The following is a description of a gene set: Human Gene Set: GSE3982_EFF_MEMORY_VS_CENT_MEMORY_CD4_TCELL_UP In the present study we used Affymetrix oligonucleotide microarrays to produce gene transcription profiles for the major leukocyte types in humans. This comprehensive dataset enabled us to not only establish which genes were expressed in each leukocyte type, but also which genes were expressed in each subset after activation. The used of a comprehensive dataset of gene profiles from all the major human leukocyte subsets enabled a novel and powerful means for identification of genes associated with single leukocyte subsets, or different immune paradigms. species: Homo sapiens from publication Jeffrey KL, Brummer T, Rolph MS, Liu SM, Callejas NA, Grumont RJ, Gillieron C, Mackay F, Grey S, Camps M, Rommel C, Gerondakis SD, Mackay CR (PMID 16474395) Genes up-regulated in comparison of effective memory CD4 T cells versus central memory CD4 T cells., and this is the list of marker genes: EXTL2, MYH4, ZNF74, TUBB3, NECTIN3, TRPM2, FGR, GZMA, DOC2B, CD8B, DNAAF1, RNLS, MSH6, RUNX3 (NCBI Gene Id 864), GNLY, ENPP4, AGBL3, SUSD6, TFF3, IFNA6, CCND1, LUZP1, RASL10A, RFX2, SZT2, TRHDE (NCBI Gene Id 29953), DLX5, NLE1, TRAPPC14, CDIP1, SP3P, ORMDL2, SNAP91, GFI1, GZMK, ANXA2P2, GZMH, ST8SIA3, PIGZ, MAP2K6, AGPAT4, MRFAP1L1, SPATA7, FZR1, CAMKV, SIGLEC8, LBHD1, ERN2, H4C7, SPRED2, SRF, ITGAM, NR2F2, AMN, BDKRB2, BHMT2, E2F8, RAP1GAP2, TBX4, ERMP1, CABP5, PARP8, HPS1, NKG7, CD300A, NHLRC2, PHACTR4, ACTR3, ZDHHC14, ABCA3, PCOLCE, ISL1, PLA2G15, GAPDH, HLA-DPB1, ADGRV1, PHYH, LDLR, GFM1, SYNE2, PKP4, MCM2, CHKA, FOXA1, ELAPOR1, EIF3I, SLC25A42, VCL, SBSPON, HOPX, MYT1L, AZI2, RIMBP2, PCSK1N, CLTC, PLA2G4C, CLCA4, MAOB (monoamine oxidase B), SPON2, WEE1, DOCK6, CALM1, PLCB3, RBMS3, RSU1, CREB3, DACT1, TNC, CLIC1, KLRB1 (killer cell lectin like receptor B1), UBB, ADAMTS1, CCN1 (NCBI Gene Id 3491), TUBA1C, NEU2, AOAH, SRBD1, DGLUCY, G0S2, MATK, KEAP1, LPXN, IL12RB2, PTGES2, ARHGAP25, ARPC5L, CSTF2, TMX4, NT5C (NCBI Gene Id 7370), ACADVL, SDF2L1, IL4, PPIA, CCDC70, MT4 (metallothionein 4), STIL, CHD9, TCTN3, MRM3, KLHL4, AGFG2, WARS2, FBXO40, LCN2, ITGB2, DAPK2, TBC1D31, IMP3, BEAN1, NRP2, JAKMIP2, GAS7, IFNA21, S100A4, TULP2, TNFRSF1B, COLEC12, STX4, DIAPH1, IFT52, RMDN3, CALML5, CACNA1E, CCL22, CH25H, ANXA2, RASSF1, B9D2, GLS2, PLXND1, DERL1, TARP, KLF8, CX3CR1, CRLF1, METTL25B, MIR22HG, BLTP1, APOBEC3G, GPER1, PLAAT4, GPD1L, THOC5 (NCBI Gene Id 8563), PITPNA, ELOVL6, SPINT3, H2BC10, PTTG2, CCDC85B (NCBI Gene Id 11007), CRY2, CAPNS1, ADA, UFD1, TOP3B, HYOU1, SUCLA2